The following is a description of a gene set: from publication Phong MS, Van Horn RD, Li S, Tucker-Kellogg G, Surana U, Ye XS (PMID 20516219) Genes whose expression changes in Calu-6 cells (lung cancer) by TNF were not affected by p38 inhibitor LY479754. species: Homo sapiens p38 mitogen-activated protein kinase (MAPK) is rapidly activated by stresses and is believed to play an important role in the stress response. While Chk1 is known to mediate G(2) DNA damage checkpoint control, p38 was also reported to have an essential function in this checkpoint control. Here, we have investigated further the roles of p38 and Chk1 in the G(2) DNA damage checkpoint in cancer cells. We find that although p38 activation is strongly induced by DNA damage, its activity is not required for the G(2) DNA damage checkpoint. In contrast, Chk1 kinase is responsible for the execution of G(2) DNA damage checkpoint control in p53-deficient cells. The inhibition of p38 activity has no effect on Chk1 activation and gamma-H2AX expression. Global gene expression profiling of cancer cells in response to tumor necrosis factor alpha (TNF-alpha) revealed that p38 plays a strong prosurvival role through the coordinated downregulation of proapoptotic genes and upregulation of prosurvival genes. We show that the inhibition of p38 activity during G(2) DNA damage checkpoint arrest triggers apoptosis in a p53-independent manner with a concurrent decrease in the level of Bcl2 family proteins. Our results suggest that although p38 MAPK is not required for the G(2) DNA damage checkpoint function, it plays an important prosurvival role during the G(2) DNA damage checkpoint response through the upregulation of the Bcl2 family proteins. Human Gene Set: PHONG_TNF_RESPONSE_NOT_VIA_P38, and this is the list of marker genes: SLC30A1, IKBKE, ABLIM3, ABCA1, KLF6, CD70, TMEM265, ARID5B, SYDE1, RAI14 (retinoic acid induced 14), MALL, TMEM204, HLA-G, ADARB1, RAB13, APBA3, SMOX, SLCO3A1, DENND5A, CD83, IGSF3, TRAF3, SGK1, HSPA1A, EFHD2, HTATSF1, TNFRSF21, MAP2K1, HYOU1, IVNS1ABP, NET1, LARP6, ZMIZ2, PLPP3, HSD17B2, DRAM1, DDA1, MED20, DNAJB1, HLA-B, FXN, NXN, TMEM50B, NBN, OXTR, BCL3, IFNGR1, RHOBTB3, RELB, MAP3K3, MYBL1, LAT, TRIM21 (NCBI Gene Id 6737), CXADR, CYP1A1, MVD, CARS1, NRP2, BID, CLK4, MMP9, DSE, TNFRSF9, HSPA1B, AMPD3, GBP1, EGFR, SBNO2, ADGRE5, CYLD, GBP2, PDE10A, CSF1, ARRB1, TNFAIP2, ETV1, ABTB2, TNIP1, DHRS2, N4BP3, TRIM16, EPHA2, NFKBIA, NFE2L1, FLOT1, RIPOR1, SEL1L, MID1, TRIP10, TPCN1, LDLR, TRIB1, TMEM156, ING3, CRELD2, LRRC49, NECAP2, SOX9, MEIS2, SLC25A22, TFE3 (transcription factor binding to IGHM enhancer 3), G0S2, PTBP3, KCNAB2, PLAU, FNBP1, SERTAD2, NMI, GFPT2, ZBTB10, SLC22A4, TMEM132A, CDKN1B (NCBI Gene Id 1027), ABR, IRF2, FOXF1, RAB11FIP2, CADM1, TANK, ABCD3 (NCBI Gene Id 5825), PHACTR4, ECE1, PLXNA1, DNMBP, RIPK2, PLAUR, PANX1, GATA6, AOPEP, NFKB1, WTAP, MGAT4B, NFKB2, LPXN, DNAJC10, TUBB2A, SOD2, CD47, PPARG (NCBI Gene Id 5468), GPRC5A, TNIP2, TNFAIP8, BIRC3, HTRA2, PDLIM5, IRS2, RCAN1, TUT4, GPRC5C, GRINA, CDCP1, CA12, RNF19B, HEY1, P4HA2, ITGA2, KLF7, IER5 (immediate early response 5), SLC25A37, PRSS23, TRIM62, RGS3, TRAF1, TGOLN2, INAVA, CLIP2, CFLAR, EHD1, HES1, GPRC5B, TNIK, BAMBI, ICAM1, FSTL3, BCL2A1, CXCL10, PHLDA2, CRYBG1, SSBP2, SSTR2, EMP1 (epithelial membrane protein 1), SAMD4A (sterile alpha motif domain containing 4A), MYH9, SH3BP4, NUP62, THAP10, DUSP8, GCH1, IL6ST, BMAL2, PHF11, LTB, HLA-A, ARHGEF40, PLCB4, GEM, ATP1B1, TRAPPC4, NR2C1, OPTN, STK10, GRK5, UVRAG, NETO2, SOX4, FZD5, MDFI, ETS1, SRPK1, GATA2, PPME1, B4GALT5, JUND, SP100, RFX5, TCF7L2, NAB1, PDE4A, SMAD3, STRA6, CREB3, MYO1C, IER2, IRF1, JPT2, C1QTNF1, MANF, VIPR1, CROT, AMOTL2, FLG, PDLIM4, DLEU2, CALD1, CSF2, MPHOSPH10, VCAN, VCAM1, MMP1, LAMC2, TNFRSF1B, GADD45A, ID2, BSDC1, PTGES, NIBAN1, BHLHE40, ARSJ, PARP12, ATF5 (activating transcription factor 5), NFE2L3, MMD, CEBPB, MEF2C, VDR, ROBO1, PEG10, MEGF9, CUL4B, DOCK4, CDC42EP3, RAC2, INF2, TNFRSF6B, CYB561, MAP2K3, PDIA4, RBM47, C2CD2, SRGN, ZFP36L2, CX3CL1, RHBDF2, RAPGEF2, JAK1, TNFRSF10B (NCBI Gene Id 8795), RHOF, LOXL2, MTUS1, SDC4, PIK3CD, TMEM158, PSMB9, IFNAR2, NR2F1, CCDC28B, PELI1, PRKCD, HSP90B1, GSAP, MMP2, TRIO, SHB, TRIB3, DNAJC3, STEAP1, PLEKHA5, ETS2, EFNA1, CNOT2, EML2, PROX1, NR2F2, HSPA5, ZNF267, LIMD2, ADAMTS9, OSR2, LRIG1 (NCBI Gene Id 26018), SERPINE1, CD58, GNAI1, PPIF, BMP5, FKBP4, WDR48, TUBD1, BHLHE41, CLDN1, GCHFR, COL6A1, SLC2A6, HSPB8, ZFHX4, SMAD1, HIVEP2, FDX1, MREG, SYNGR2, NAV2, INPP4B, ADGRA3, COL6A2, ZNF432, ANKLE2, ZBTB18, SLCO4A1, CSNK1G2, OGFR, JUN, TOX